Given this list of marker genes H2BC3, H2AC16, H3C14, H4C1 (H4 clustered histone 1), H2BC7, MTA3, HMG20B, H2AC1, H2BC21, H4C9, H2BC4, H4C12, SUDS3, CHD3, H4C5, SAP18, H3C15, H4C3, HDAC1, H3C7, H4C8 (NCBI Gene Id 8365), MTA2, H4C6, HDAC2, H2BC8, RBBP4, H2BC13, RCOR1, H2AC13, H2AC18, H2BC6, H3C13, H4C15, H2BC11, MTA1, H2AC15, H2BC10, H4C2, H3C6, MBD3, H2BC14, BRMS1, H2AC14, KDM1A, H2BC5, H2BC18, H3C11, H3C8, H4C13, GPS2, H2AC19, ARID4A, H4C14, TBL1X, H3C2, H2AC25, GATAD2B, H2BC15, H2BC26, HDAC8, H3C3, H4C4, NCOR1, HDAC10, H2AC7, GATAD2A, H2AC21, H3C1, NCOR2, H3C4, H2AC11, H2AC12, ARID4B, TBL1XR1, H2BC1, RBBP7, H2BC12, H4C16, H2AC8, H2BC9 (H2B clustered histone 9), H2AC6, SAP30, HDAC3, H2AC17, H4C11, PHF21A, H2AC20, REST, SAP30L, H3C12, H3C10, CHD4, H2AC4, H2BC17, here is a description of the gene set: species: Homo sapiens Human Gene Set: REACTOME_HDACS_DEACETYLATE_HISTONES HDACs deacetylate histones